Given this list of marker genes ITGA4, CCSER1, EEPD1, CDK1, CA9, CCNA2, MFSD10, WDR41 (NCBI Gene Id 55255), CDC42EP3, TSPOAP1, ANP32E, IQGAP1, LAIR1, AURKA, LAMTOR1, PDGFB, PLK4, RAP1GAP2, FCHO2, IMMP2L, NPC1, CSGALNACT2, RNF149, GCNT2, NAGPA, CRLF2, SEMA4D (NCBI Gene Id 349236), CYTH4, UGGT1, UBE2E3, TOPBP1, GKAP1, CHTF18, EPS15L1, TRAPPC14, MYO1H, ASAP2, USP11, LANCL2, PACC1, SLC25A39, DUSP16, PTGR1 (prostaglandin reductase 1), SPC25, ERLIN1, CENPF, LPCAT2, NRM (nurim), RBPJ (recombination signal binding protein for immunoglobulin kappa J region), PAICS, RRAGC, PAPSS1, CCRL2, ATF6, MAP4K5, CDYL2, TSPAN31 (tetraspanin 31), ESCO2, GFPT1, CENPS (centromere protein S), SORL1, LIPE, PTPN3, RNF135, ATP5IF1, FCGRT, PGAP6, MFSD12, TRIM36, DECR1, MALT1, KCNE3, CCNF, SMC2, ASB2, SNX10, EML3 (EMAP like 3), LITAF, CYBA, TK1, SLC2A3, NOSTRIN, FAM174A, ACTR1B (actin related protein 1B), ELAC1, TYMS (NCBI Gene Id 7298), APOBEC3B, TFDP1, PRKRA, CARMIL1, DIAPH2, TAX1BP3, FLVCR1, TBC1D4, NLRP3, CD40, CADM3, GNG2, TMED3, DNAJB14, RRBP1, BRI3, RASGRP3, MED30, MFSD14B, ELMO1, MCM7, SBNO2, RFC2, APP, CXCL10, SPAG5, ITPR1, PFKFB4, SULF2, SH3BGRL (NCBI Gene Id 96022), TMEM100, SUPT3H, MCM4, ELL2, DEK, NAP1L1, IAH1, CKS2, NDST1, BID, RAB31, HSD17B12, BACH1, PLA2G4A, CTBP2, AURKB, ZNF516 (zinc finger protein 516), STMN1, DLGAP5, BIRC3, TRIT1, ARHGAP21, SNORD89, EME1, SLC4A8, WDR13 (WD repeat domain 13), MAPRE2, SLAMF7, GPX1, DYNLT2B (NCBI Gene Id 255758), MOB1A, B4GALT4, CD79B, ABI3, NEURL2, CEBPD, NOD1, AKT1, ZCCHC3, SYCE2, NSD2, KRT80, ATAD2, PRRC1, LMAN2, SIGLEC7, HAT1, UGDH, TEX9, SLC6A12, IFT172, ADORA2B, PTK2, NCKAP1L, ADAM17, PRKCB, TTK, N4BP3, TPX2, GSG1, CACNB3, CHKA, ADAM11, ISCU, CDCP1, FAR1, VAMP8, HAUS5, ID2, BUB1, CEP55, NFKBIE, TNFAIP8, SERINC3, SLBP, DOCK1, FIGNL1, RCAN1, POLD4, FBXW8, MAP3K14, C11orf54, NCAPG2, AP1S2, here is a description of the gene set: We noticed that ThPOK repression is readily abrogated upon in vitro TCR stimulation of peripheral CD8 T cells. This observation prompted us to investigate a role of ThPOK in the CD8 T cell response to an acute viral infection. We observed that clonal expansion is significantly less in both primary and secondary CD8 T cell responses in the absence of functional ThPOK. To approach this mechanism, we carried out a microarray analysis for comparison of gene expression between ThPOKhd/hd and ThPOKwt/wt P14 memory T cells. from publication Setoguchi R, Taniuchi I, Bevan MJ (PMID 19734230) Human Gene Set: GSE17812_WT_VS_THPOK_KO_MEMORY_CD8_TCELL_DN species: Homo sapiens Genes down-regulated in memory CD8 T cells: wildtype wt versus ZBTB7B knockout.